The following is a description of a gene set: studied in species Mus musculus Mouse Gene Set: REACTOME_MYOGENESIS Myogenesis, and this is the list of marker genes: Mapk14, Bnip2, Tcf12, Abl1, Ctnna1, Myog, Mef2d, Cdon, Cdh15, Cdh4, Mef2c, Mapk11, Mef2b, Ctnna2, Myf6, Cdh2, Spag9, Myod1, Tcf3, Tcf4, Cdc42 (NCBI Gene Id 12540), Mapk12, Myf5, Ctnnb1